The following is a description of a gene set: species: Homo sapiens part of: Deubiquitination Reactome Pathway: Metalloprotease DUBs The JAB1/MPN +/MOV34 (JAMM) domain metalloproteases cleave the isopeptide bond at or near the the attachment point of polyubiquitin and substrate. PSMD14 (RPN11), STAMBP (AMSH), STAMBPL1 (AMSH-LP), and BRCC3 (BRCC36) are highly specific for the K63 poly-Ub linkage, which may be a general characteristic (Eletr & Wilkinson 2014). The proteasome 19S lid complex includes PSMD14, an endopeptidase that cleaves poly-Ub chains from substrates as they are degraded by the proteasome. The COP9-Signalosome contains COPS5 (CSN5), which deconjugates the Ub-like modifier Nedd8, modulating the activity of the SCF E3 ligase. <br><br>JAMM DUB catalysis requires nucleophilic attack on the carbonyl carbon of the isopeptide bond by an activated water molecule bound to Zn2+ and a conserved glutamate. A negatively-charged tetrahedral transition state ensues, and a nearby conserved Ser/Thr in the JAMM domains stabilizes the oxyanion. The tetrahedral intermediate then collapses and the Glu serves as a general base donating a proton to the leaving Lys side chain., and this is the list of marker genes: STAMBP, UBA52, BABAM1, H2AC25, H2AC12, BRCA1, STAM, H2AC6, BARD1, EP300, NLRP3 (NLR family pyrin domain containing 3), H2AC18, UBB, UIMC1, H2AC21, ABRAXAS2, H2AC4, MYSM1, H2AC14, BABAM2, H2AC1 (NCBI Gene Id 221613), STAMBPL1, H2AC20, KAT2B, H2AC11, H2AC7, UBC, ABRAXAS1, PSMD14, BRCC3, RPS27A